The following is a description of a gene set: MSH6 encodes a G/T mismatch-binding protein encoded by a gene localized to within 1 megabase of the related hMSH2 gene on chromosome 2. Unlike other mismatch repair genes, the MSH6 deficient cells showed alterations primarily in mononucleotide tracts, indicating the role MSH6 plays in maintaining the integrity of the human genome. Cells deficient in MSH6, accrue mutations in tracts of repeated nucleotides. MSH6 defects seem to be less common than MLH1 and MSH2 defects. They have been mostly observed in atypical HNPCC families and are characterized by a weaker family history of tumor development, higher age at disease onset, and low degrees of microsatellite instability (MSI) that predominantly involving mononucleotide runs. part of: Diseases of Mismatch Repair (MMR) Reactome Pathway: Defective Mismatch Repair Associated With MSH6 studied in species Homo sapiens, and this is the list of marker genes: MSH2, MSH6